The following is a description of a gene set: species: Homo sapiens The process in which the egg becomes metabolically active, initiates protein and DNA synthesis and undergoes structural changes to its cortex and/or cytoplasm. Human Gene Set: GOBP_EGG_ACTIVATION, and this is the list of marker genes: ZP2, MYH9, WBP2NL (NCBI Gene Id 164684), PLCZ1, PLCB1, NLRP5, PLAT, TPST2, ZP1, ZP4, ASTL, NPR2